The following is a description of a gene set: from publication Haralambieva IH, Ovsyannikova IG, Kennedy RB, Zimmermann MT, Grill DE, Oberg AL, Poland GA (PMID 27317456) Genes positively correlated with memory B cell response at 28d in peripheral blood mononuclear cell in seniors (50-74) after exposure to Fluarix, time point 3D species: Homo sapiens BACKGROUND: Studies suggest that the recall-based humoral immune responses to influenza A/H1N1 originates from activated memory B cells. The aim of this study was to identify baseline, early and late blood transcriptional signatures (in peripheral blood mononuclear cells/PBMCs) associated with memory B cell response following influenza vaccination. METHODS: We used pre- and post-vaccination mRNA-Seq transcriptional profiling on samples from 159 subjects (50-74years old) following receipt of seasonal trivalent influenza vaccine containing the A/California/7/2009/H1N1-like virus, and penalized regression modeling to identify associations with influenza A/H1N1-specific memory B cell ELISPOT response after vaccination. RESULTS: Genesets and genes (p-value range 7.92E(-08) to 0.00018, q-value range 0.00019-0.039) demonstrating significant associations (of gene expression levels) with memory B cell response suggest the importance of metabolic (cholesterol and lipid metabolism-related), cell migration/adhesion, MAP kinase, NF-kB cell signaling (chemokine/cytokine signaling) and transcriptional regulation gene signatures in the development of memory B cell response after influenza vaccination. CONCLUSION: Through an unbiased transcriptome-wide profiling approach, our study identified signatures of memory B cell response following influenza vaccination, highlighting the underappreciated role of metabolic changes (among the other immune function-related events) in the regulation of influenza vaccine-induced immune memory. Human Gene Set: HARALAMBIEVA_PBMC_FLUARIX_AGE_50_74YO_CORR_WITH_28D_MEM_B_CELL_RESPONSE_AT_3DY_POSITIVE, and this is the list of marker genes: PSMB7, EIF2AK2, IL1B, HSF1, TAF13, KPNA2, SMURF1, SULT1B1, TWF1, TNFRSF21, EAF1, VTI1B, LCOR, SLK, CXXC5 (NCBI Gene Id 51523), BNIP2, IDI2-AS1, CDKN1A, TGFBRAP1, NBPF10, DCTN4, ZBED4, SFT2D2, HBP1, MICAL2, EMC6, NUBP1 (NUBP iron-sulfur cluster assembly factor 1, cytosolic), RAB33B, MLXIP, ZNF551, UVSSA, UGCG, MAP1LC3B2, RAB30, ID2B, ZNF184, SPTY2D1, SMARCB1, ISG20L2, CERS6, ATP6V0C, RREB1, SOCS1 (NCBI Gene Id 8651), JARID2, INO80B, IKZF5, CSGALNACT2, BMAL2, HSPA13, POLR2M, PPP1R15B, PPP4R2, ICOSLG, PJA2, PPP4R1L, ZNF614 (zinc finger protein 614), DDX3X (DEAD-box helicase 3 X-linked), DDX21, TXNDC5, CDC40, ZFR, AP5B1, TMED7, ABRAXAS2, GALNS, ZNG1B, RPL7L1, SOCS4, C2orf69, NFKBIA, YPEL2, BOP1 (BOP1 ribosomal biogenesis factor), CBX6, GNA11, TMED7-TICAM2, C17orf107, SLC7A5, MED21, SNX13, ARL5B, CHPT1, RGS7, IL1RAP, RSRC1, MRPS22, SNTB1, SLC38A7, CCNK, HOXA5, LRRK1, SHANK1, KCNC3, ARL8A, EXT1, OPN3, NCF1C, CWC25, STK17B, BCL2L2-PABPN1 (BCL2L2-PABPN1 readthrough), IRAK1, SLC25A30, C2orf49, SLC25A34, SLC9A7, NPEPL1, GNA12, ZNF304, PXDC1, H3-5, ETV3, NATD1, FEM1C, GRAMD1B, MEX3B, CIC, ZNF124 (zinc finger protein 124), QTRT2, ARF1, ZFP92, VRK2, KPNA3, ZNF93, PANK3, MEMO1, RAB5C, MAPK8, DHX8, ITPRIP, CCDC86, LMTK2, GUCD1, NRIP1, IER2, GRPEL1, SIPA1L3, DCUN1D1 (NCBI Gene Id 54165), PLEKHM2, PRKCE, TNFRSF12A (NCBI Gene Id 51330), OLR1, CDK14, IRF4, FEM1A, RIPK2, MROH1, TNFRSF10B (TNF receptor superfamily member 10b), ELF1, USP3, MIDN, MUL1, NFKBIZ, SIRT1, ZCCHC2, NOCT, AP3B1, MAPK7, KRR1, GMEB1, NAB1, USP38, IL1A, MKRN9P, FAM53C, MAP2, SCML1, ANAPC15, VEGFA, SERINC1, ZNF324, CIITA, INCENP, HIC2, XXYLT1, ZNF689 (NCBI Gene Id 553125), SAPCD2, FRMD8P1, FOSL1 (FOS like 1, AP-1 transcription factor subunit), TREML4, TMEM199, HBEGF, CHRM4, EGR1, ZFP91-CNTF, REL, LRRC59, SENP2, MFSD14A, YJU2, DYM, KHSRP, SIK1, CCDC69 (coiled-coil domain containing 69), FAF2, TOR1AIP1, PIP5K1C (phosphatidylinositol-4-phosphate 5-kinase type 1 gamma), DIP2B, MED13L, GINM1, ZFP36, ADM, GPR84, KREMEN1, ZDHHC20, FOXO4, MLX, ASTL, PFKFB3, JMJD1C, STX10, PCDHGC3, C11orf96, POM121, POLR1F, G0S2, NR4A3, PRXL2C, ZNF844, WASHC2A, SOCS3, NIPAL2, TSNARE1, PLEKHM3, MOB1A, ZFP91, PXK, NRROS, KCNQ1 (NCBI Gene Id 3784), ETS2, TMEM167B, RAB11FIP2, CEBPB, TMEM38A, ZNF487, EIF3A, ATP11C, GTF3C4, KSR1, FOSL2, TNFRSF13C, RASGEF1B, SNIP1, PGAM2, GGN, SRRD, ADAM17, DUSP10, MAPK6, SKIL, MYLIP, GLUD2, MIER3, PER1, KCTD3, KLF10, PPM1L, IKBKG, TBC1D9B, PHLDA2, PTP4A1, PELI1, ATP2A2, ACO2, METTL14, SLC2A3, KLF7, PELI2, NFIL3, CCDC6, ZBTB21, TSC22D2, KIAA1958, FOXN3, TBC1D14, IL6, LRRC4, STARD4, H2AC25, AHR, IER3, EPS15L1, GNAQ, NUDT3, TMEM183A, EME2, FAM117B, PNO1, GANC, HINT3, SRGAP2B, ASAP1, CARD19, SYNE3, NBPF9, ZBTB10, ZC3H12A, TNFAIP6, PNPLA2, ZNF791, EIF4H, RAF1, MED26, BCL6, KDM6A, DNAJC11, USP6NL, BHLHE40, BLTP3B, FCHSD2, ARL15, ENSG00000272447 (NCBI Gene Id 642361), CYC1, VTI1A, LGALS8, PDZD8, MTM1, SNX29, ZNF511, SNAI1, TRAM1L1, EIF3C, UVRAG, MAP3K3, STRN4, ICAM1, YTHDF3, TESK2, ZFAT, PNPLA8, SMPD4, ZNF496, KLHL15, PIM3, UAP1L1, WASHC2C, NFKBID, GPM6B, COIL, BPI, CCDC186, ZBTB43, ANO8, KAT5, ZNF281, ARSG, HIF1A, GEM, BCL3, ID2, CDK8, ACSL1, IRS2, NFIC, PPTC7, PPP1R15A, GMFB (glia maturation factor beta), MAPRE1, KLF4, TNFAIP3, APP, SNX12, PPP1R2B, PPP2R5E (protein phosphatase 2 regulatory subunit B'epsilon), PGK2, SERTAD2, FNDC3B, KLF5, SEC24B, GRIK5